Given this list of marker genes PORCN, here is a description of the gene set: Aberrant WNT signaling is associated with the development of numerous cancers, and strategies for targeting this pathway are under intense investigation. Secretion of WNT ligand depends on its PORCN-dependent palmitoleoylation in the ER, making PORCN a attractive therapeutic target in cases where WNT is aberrantly over-expressed. LGK974 is a PORCN-inhibitor that was identified in a screen for compounds that abrogate the secretion of WNT ligands, and is in Phase I clinical trials for the treatment of WNT-dependent cancers part of: Signaling by WNT in cancer Reactome Pathway: LGK974 inhibits PORCN studied in species Homo sapiens